Given this list of marker genes App, Prnp, Abcd2, Psen1, Map1a, Ins1, Abcd1, Ins2, Atp1a3, Dctn1, Adcy10, Insr, Ephb2, Kifbp, here is a description of the gene set: The organization process that preserves a neuron projection in a stable functional or structural state. A neuron projection is a prolongation or process extending from a nerve cell, e.g. an axon or dendrite. species: Mus musculus Mouse Gene Set: GOBP_NEURON_PROJECTION_MAINTENANCE